Given this list of marker genes COL8A2, LRBA, FAM117B, BRI3BP, SMARCA2, ACSM3, SNAP23, RALB, ALDH6A1, EVI2A, ZRSR2, TK2, PBX3, ENTREP3, SMAP2, RPS6KA5, MCM6, CREB3L2, ALAS1, PAK1, ING1, OSCP1, PLCL2, FKBP1A, KAT2B, APOBEC3A, CNPY3, HAVCR2, CARD9, DUSP10, ST6GAL1, SLC25A45, SDHAP1, TRAM1, SDS, WDR41, HACD4, EHMT2, CORO1C, COG6, KLF4, HPS4, RITA1, DIAPH1, FRMD3, SIGLEC1, PLXNB2, SORD, CMTR1, NOD2, GLT1D1, XPO7, AP3S2, PPP1CC, PITHD1, CPPED1, SEPTIN4, PIK3IP1, L3MBTL3, JAK2, ZNF248, LIX1L, MYD88, SLC2A13, RCBTB2, CLSTN1, DHX58, RIGI, RNLS, RBL2, AFG2A, ANXA1, SLAIN1 (NCBI Gene Id 122060), TOP1MT, MIDEAS, ITGAM, CCDC112, HPS3, ABHD2, TPI1, RAD51, PARP9, FYB1, LIG1 (NCBI Gene Id 3978), ZNF785, EEIG2 (NCBI Gene Id 284611), TMT1B (NCBI Gene Id 196410), EPRS1, SLC18A1, FANCD2, CTDSP1, HSPA8, FDXR, CLEC10A, NUDT7, MYO18A, ARL11, C2, C4orf33, ING4, GINS1, SLC15A4, SLC49A3, GBP2, FAM21EP, EIF2AK1 (NCBI Gene Id 27102), HSPBAP1, PAQR8, TMC6, MYO1F, LPAR6, ZNF775, IL18BP, KIAA0513 (KIAA0513), PFKM, IRF2, ERMP1, NARS1, THNSL1, DLAT, NTAQ1, OMA1, TEX14, IFI35, TCN2, ACAA1, SARAF, AGPAT5, RAB32, CHST12, MTHFR, ATG3, RNH1, HLA-DMA, USP30-AS1, TMEM106B, NAPA, DOCK5, ADCY7, SLFN11, C1orf174, STARD13, USP6NL, HK1, SLC9A9, PDS5B, TRIM21, MICU1, MKRN1, ZNF689, CA5B, UBXN11, DECR1, CDK5RAP3, ECHDC1, IDNK, CD46, ETFRF1, HLA-B, CSF3R, PRCP, INTS3, FBXO6, RGS18, PRDM13, DNPEP, WIPF1, IL2RG, LRRC37A2, RUBCN, RCSD1, NT5M, FECH, LINC00324, GNG7, CYP2S1, MGST2, ORAI3, CAMK1D, CEP85, STX10, PGRMC1, CXCR4, OSGEPL1, IL17RA, RNF138, ERRFI1, HLA-A, OXNAD1, MOV10, ZNF395, PRIM1, ATP6V0A1, FAM111A, PYCARD, UVRAG, SPIRE1, PGM2, ATG16L2, FLOT2, here is a description of the gene set: Gene expression analysis of freshly isolated CD14+ human monocytes and monocytes cultured in the presence or absence of interferon (IFN) -gamma for 24 h and then stimulated with Pam3Cys, a Toll-like receptor (TLR) 2 ligand, for 6 h. Results provide insight into mechanisms by which IFN-gamma reprograms early macrophage differentiation and subsequent response to TLR ligands. studied in species Homo sapiens from publication Hu X, Chung AY, Wu I, Foldi J, Chen J, Ji JD, Tateya T, Kang YJ, Han J, Gessler M, Kageyama R, Ivashkiv LB (PMID 18976936) Human Gene Set: GSE11864_CSF1_IFNG_VS_CSF1_PAM3CYS_IN_MAC_UP Genes up-regulated in comparison of macrophages cultured with M-CSF and IFNG versus macrophages cultured with M-CSF and Pam3Cyc.